The following is a description of a gene set: Mouse Gene Set: GOBP_NEGATIVE_REGULATION_OF_CHRONIC_INFLAMMATORY_RESPONSE species: Mus musculus Any process that stops, prevents, or reduces the frequency, rate, or extent of a chronic inflammatory response., and this is the list of marker genes: Cx3cr1, Tnfaip3, Il4, Il10, Cyp19a1, Foxp3